The following is a description of a gene set: Genes up-regulated in peripheral blood mononuclear cell 1d vs 0d in adults after exposure to Inactivated influenza vaccine, time point 1D. Comment: Up-regulated DE RNA transcripts (up >= 1.5x) shared between both TIV-vaccinated donors Human Gene Set: HOEK_PBMC_INACTIVATED_INFLUENZA_ADULT_1DY_UP from publication Hoek KL, Samir P, Howard LM, Niu X, Prasad N, Galassie A, Liu Q, Allos TM, Floyd KA, Guo Y, Shyr Y, Levy SE, Joyce S, Edwards KM, Link AJ (PMID 25706537) Systems biology is an approach to comprehensively study complex interactions within a biological system. Most published systems vaccinology studies have utilized whole blood or peripheral blood mononuclear cells (PBMC) to monitor the immune response after vaccination. Because human blood is comprised of multiple hematopoietic cell types, the potential for masking responses of under-represented cell populations is increased when analyzing whole blood or PBMC. To investigate the contribution of individual cell types to the immune response after vaccination, we established a rapid and efficient method to purify human T and B cells, natural killer (NK) cells, myeloid dendritic cells (mDC), monocytes, and neutrophils from fresh venous blood. Purified cells were fractionated and processed in a single day. RNA-Seq and quantitative shotgun proteomics were performed to determine expression profiles for each cell type prior to and after inactivated seasonal influenza vaccination. Our results show that transcriptomic and proteomic profiles generated from purified immune cells differ significantly from PBMC. Differential expression analysis for each immune cell type also shows unique transcriptomic and proteomic expression profiles as well as changing biological networks at early time points after vaccination. This cell type-specific information provides a more comprehensive approach to monitor vaccine responses. species: Homo sapiens, and this is the list of marker genes: IGLV6-57, IGKV2-30, GEMIN7-AS1, IGKV1-9, IGLV7-43 (immunoglobulin lambda variable 7-43), IGKV1D-12, IGLV1-47, CLEC6A, IGLV3-25, SLX1B (SLX1 homolog B, structure-specific endonuclease subunit), HYAL3 (hyaluronidase 3), IGKV2D-30, ICAM5